Given this list of marker genes PIK3R1, CHN1, VSX1, IGF1R (NCBI Gene Id 51049), HHAT, NDP, FGFRL1, PAX6, WT1, ERCC6, PAX3, FGFR1, FBN1, SALL4, MAFB (MAF bZIP transcription factor B), CTBP1, MITF, SOX10, ITPR1, HS2ST1, MIR184, PORCN, NSD2, LRP2, STIM1, LETM1, WDR73, FOXC1, LAMB2, PITX2, CPAMD8, CPLX1, ADAMTSL1, COL4A1, TRIM44, here is a description of the gene set: studied in species Homo sapiens Congenital underdevelopment of the iris. Hypoplasia of the iris Human Gene Set: HP_HYPOPLASIA_OF_THE_IRIS